The following is a description of a gene set: LYVE-1-positive macrophages were observed to be closely spatially associated with the developing lymphatic vasculature. The role of this population of macrophages in the embryo is uncharacterised. We used microarray analyses to investigate which genes are differentially regulated between LYVE-1-positive and LYVE-1-negative macrophages Genes down-regulated in macrophages: LYVE1+ versus LYVE1-. Human Gene Set: GSE24492_LYVE_NEG_VS_POS_MACROPHAGE_DN studied in species Homo sapiens from publication Gordon EJ, Rao S, Pollard JW, Nutt SL, Lang RA, Harvey NL (PMID 20978081), and this is the list of marker genes: MYH3, NTF4, SIRT2, CD4, UNC13A, DIABLO (NCBI Gene Id 56616), MKRN1, FBXO6, C1R, DSTYK, DMBX1, TBX3, CSGALNACT1, CAVIN2, NXNL2, CRYAB, HSPG2, BARHL1, ITGB2, NKX2-8, DEPP1, DNAH9 (dynein axonemal heavy chain 9), GALNT15, TMEM54, CELA1, CHST3, FBLN5, FAM219B, HEXA, SIDT2 (SID1 transmembrane family member 2), TMEM203, BRINP2, GREB1L, BCL7B, LZTS3, MRPL44, IGHG1 (immunoglobulin heavy constant gamma 1 (G1m marker)), SULT4A1, DGKG, NMU, STRADB, PTCRA, CBFA2T2, UBOX5, CRYBB1, UBR7, NIPA1, BBS1, FAM162B, COL16A1, SCN2B, UBXN11, SLC37A2, ARVCF, TUSC2, ADGRE1, FPR1, GTF2A1L, NEUROG1, FAM50B, NEUROG3, SPRR3, NCAM1, LARGE2, PLPP5, CFAP52, ZNF454, GABRQ, C4orf46, ASB2, DUSP6, FAP, ADAMTS2, BCL2L10, FAM149B1, AP1B1 (adaptor related protein complex 1 subunit beta 1), PCDH8, IDUA, FSD1, VEGFA, SPOCK3, SPINK8, PGPEP1, RPP14, EDN3, SLC18A1 (NCBI Gene Id 6570), CATSPERG, AREL1 (NCBI Gene Id 9870), USF3, CTSA, NF1, HFE, ZNF704, OR52A1, SMIM12 (NCBI Gene Id 113444), CKB, WSB2, SH2D1A, TMEM151A, GRM7, VEGFC, AKR1D1, DDX19B, ATF7IP2, GALNT9 (polypeptide N-acetylgalactosaminyltransferase 9), MGAT3, FAM184A, ACTRT1, STOML1, PAPOLB, MICALL1, BCO2, PTPN9, CCDC90B, HK2, HIC2, SIRPA, SULT1B1, PSD4, LPCAT1, NAV2, CCDC120, PSEN2, CHRNG, CCDC183, EIF2AK3, HVCN1, HTATIP2, GAST, CDK7, RTN4R, SPRED3, TCN2, ST6GAL1, ANKH, MR1, OLFML1, SMN1, UEVLD (UEV and lactate/malate dehyrogenase domains), IL12RB2 (interleukin 12 receptor subunit beta 2), ZNF784, NANOG, CRMP1, FRMD4B, SLC26A2, QKI, ADHFE1, OSBPL9, RNF31, BFSP1, ARID2 (NCBI Gene Id 57676), RAP2A, GGT1, ADAMTS5, IGHMBP2, P2RY12, NLGN1, SLC4A3, RPE65, CYB5A, LSAMP, GARIN3, SDCBP2, HAPLN1, NUDT18, RABL2A, VIT, PLG, RAB27B, SSTR4, GSKIP, MS4A3, P2RY13, TFF3, GPR174, MAN2A1, ARAP2, UGT3A2, P2RX7, SLCO6A1, CACNG2, GAPDHS, SARM1, CLTB, GALNT4, FOCAD, ANGPTL8, BICDL2, RAB20, IFI30, NKIRAS2, ITGA4, RNASE2, POLM, MSMB, MAP3K20, TFPI, CCR4, ATXN10, LHX5